The following is a description of a gene set: studied in species Mus musculus Any process that results in a change in state or activity of a cell (in terms of movement, secretion, enzyme production, gene expression, etc.) as a result of a bile acid stimulus. Mouse Gene Set: GOBP_CELLULAR_RESPONSE_TO_BILE_ACID, and this is the list of marker genes: Nr1h4 (nuclear receptor subfamily 1, group H, member 4), Gpbar1, Abcb4, Kcnmb1, Dgkq